Given this list of marker genes TCF4, SUCLG1, CCND1, APOB, RNU4-2, FAS, EFL1, PRDX1, SLC46A1, CYP7A1, TTPA (NCBI Gene Id 7274), OCRL, DLAT, SEMA4D, MTTP, CLDN16, ACSF3, FOCAD, SLC52A1, TCN2, DNAJC21, UROS, SLC10A1, FBLN5, MTRR, HLA-DQA1, SLC34A1, SIM1, FASLG, AKR1D1, CYP2R1, TTR, CASP10, MST1, MMAA, SBDS, SLC34A3, MMP1, LRP5, LMBRD1, SAR1B, RPL11, SLC37A4, GBA2, BCO1, VDR, ACOX2, MTHFD1, ALDH4A1, GALT, HLA-DQB1 (NCBI Gene Id 7924), GATA1, SPTBN1, ENPP1, FARSB, SLC30A10, MMADHC, IARS1, CLCN5, FTCD, CUBN, GUCY2C, FGF23, CBLIF, SAMD9, RNF13, GRM7, CYP27B1, ALDH18A1, RPS10, ABCD1 (ATP binding cassette subfamily D member 1), CD320, GALNT2, KL, SUCLA2, COL7A1, MMACHC (metabolism of cobalamin associated C), CYP7B1, OTUD5, HCFC1 (NCBI Gene Id 8267), ALDH6A1, ELN, SLC51B, MTR, DZIP1L, GALNT3, CTNS, CYP3A4, PTH1R, ABCD4, AMN, DMP1 (dentin matrix acidic phosphoprotein 1), AMACR, PNPLA8, ZNF699, PKHD1 (PKHD1 ciliary IPT domain containing fibrocystin/polyductin), SLC19A1, MMAB, DHFR, GPR35, MMUT, TJP2, here is a description of the gene set: species: Homo sapiens Human Gene Set: HP_ABNORMALITY_OF_VITAMIN_METABOLISM An anomaly in the metabolism of a vitamin. Abnormality of vitamin metabolism